Given this list of marker genes RND1, ARHGAP35, RPL30, RDX (NCBI Gene Id 5962), RPL29, CAP1, PTK2, RPL21, RPS6KA2, COL9A1, RPLP2, COL5A2, 5S rRNA, TUBB4A, PIK3R1, TREM2, NRAS, LDB1, TRIO, ARPC5, ZSWIM8, FRS2, SEMA4A, ABLIM1, RPS11, RPS16, SCN4A, RELN, PSMA1, TUBA8, GRB10, DCX, RPL10A, EIF4G1, ABL1, NGEF, MAGOHB, RPL26, UNC5D, FES, PSENEN, EPHB2, COL2A1, EFNA2, RPS23, CD24, AP2A1, RGMB, CSNK2B, RPL17, CLTB, ARPC3, TUBAL3, SRGAP1, CACNA1S, DSCAM (DS cell adhesion molecule), LHX9, VAV3, LIMK2, LAMB1, CACNA1H, SPTBN4, PSMD2, PSMB5, SCD5, PSMD6, RPS6KA6, MYL12B, ERBB2, PSMC2, PRKCQ, ABL2, RPS27L, TUBA1A, GSPT2, TRPC1, UNC5A, HJV, PLXNA1, MYH14, COL4A2, LYN, GSK3B, DLG1, EIF4A3, ROBO2, RET, VASP, ADRM1, RPS27A, CD72, DOK2, UBA52, KCNQ2, HOXA2, AP2M1, RPL35, ROCK1, NTN1, RPL31, RPL27A, COL4A5, SCN9A, AP2B1, MET, RPL18A, DPYSL4, EVL, CXCR4, SRGAP2, YES1, RPS7, PLCG1, CUL2, LHX3, NRP1, PSMB2, PIK3CA, NRP2, GSPT1, 5.8S rRNA, ST8SIA2, TUBA4A (NCBI Gene Id 93373), RPL28, RPL9, RAP1GAP, RPLP1, SDCBP, GFRA3, PMP22, PIK3R3, CREB1, PLXNC1, PSMC5, NFASC, EGFR (epidermal growth factor receptor), NTN4, PSMB1, VAV2, RHOA, PLXNB1, MAG, PRKACB, UPF3B, RPL23, TIAM1, AP2A2, RPS4Y2, LAMC1, FLRT3, ADGRG6, LHX2, RPL11, SCN1A, NCBP1, PSMD3, ARHGEF12, PSMD7, TLN1, CNTN6, TUBB2B, SHTN1, RPL34, SRGAP3, NAB2, EPHA2, RGMA, EFNB3, ARHGEF28, EPHB4, DAB1, CFL1, RPL13A, SHANK3, PLXNA2, COL5A3, VLDLR, DNM2, UNC5B, RPL32, RPS3, COL6A6, COL6A5, LYPLA2, DOK4, KCNQ3, LHX4, CDC42, TUBA3C, MAP2K2, ISL1, HMGCR, CASC3, TYROBP, RPL12, AP2S1, PIP5K1C, PSMA6, UBC, PSMA5 (NCBI Gene Id 5686), PLXNA3, PFN1, ARHGAP39, DRP2, EPHB1, DAG1, CNTNAP1 (NCBI Gene Id 8506), PSMC4, TUBA3E, ARHGEF7, MPZ, ARTN (artemin), PLXNA4, PTPRA, RRAS (NCBI Gene Id 6237), RPS9, SOS2, NCAN, NCAM1, MYH11, EFNA1, SCN3B, PTPN11, HRAS, NRCAM, ITGB1, HSPA8, RPL7, KIF4B, MMP2, RPL10L, SOS1, CLASP2, UTRN, RASA1, COL4A1, NCSTN, RPL3L, TUBA1C, SEMA6D, SLIT2, AGAP2, SPTA1, ROBO3, RPL37, PTPRC, SPTBN5, GRB2, SCN11A, PSPN, RPL36AL, NCK1, SH3KBP1, KRAS, UPF3A, KIF4A, RPL39L, SOX10, ITGB3, EPHA6 (NCBI Gene Id 647649), ITGA2, COL9A3, DOCK1, SEM1, GFRA2, TUBB1, RPLP0, TUBA1B, PAK4, ITGA2B, GRIN2B, RPS6, APH1B, PRX, SEMA3E, RPS18, POU3F1, L1CAM, TUBB2A, PSMC1, NCBP2, ITGA10, PDLIM7, ADGRV1, UBB, MAPK3, PAK3, SMARCA4, CLTCL1, PSMB7, HSP90AA1, ITSN1, COL6A1, RPS5, GRB7, NAB1, MYL9, APH1A, PSMA4, RPL27, CACNB3, PRKAR2A, MSN, TRPC5, NCK2, EPHB3, PSMD13, CRMP1, ARPC4, ARPC1B, RPS14, UNC5C, RPS15 (ribosomal protein S15), RHOC, CHL1, RPS19, ACTG1, PABPC1, SCN4B, PAK5, PSMD14, MYH9, SCN5A, ARPC1A, MBP, SPTBN1, CDK5R1, SRC, LAMA2, CAP2, MAPK1, RPL35A, GAP43, PSEN1, PSMD12, ITGAV, DSCAML1, RPL37A, RPS6KA1, ETF1, RPS28, RPS4Y1 (ribosomal protein S4 Y-linked 1), PSEN2, PAK6, WWTR1, KALRN, SCN3A, TEAD1, COL9A2, MAGOH, RPS17 (NCBI Gene Id 6218), ANK3, RPL23A, RANBP9 (NCBI Gene Id 10048), RPS6KA3, RPS20, GPC1, DPYSL3, RPL14, DNM3, SREBF2 (NCBI Gene Id 6721), AGRN, RPS4X, ABLIM2, SH3GL2, PRKACA, PSMD8, SCN2A, PRKACG, RPL4, 28S rRNA, WASL, EFNB1, EFNA4, COL3A1, 18S rRNA, RPS8, CDK5, EPHA7, PLXND1, CNTN2, RNPS1, CACNA1D, MMP9, MYO10, HSP90AB1, RPS10 (ribosomal protein S10), SDC2 (syndecan 2), MYL6, USP33, PSMA7, UPF2, ITGA5, CNTN1, CACNB2, RPL36A, PSMD1, ARPC2, TRPC3 (NCBI Gene Id 7222), GFRA1, PSMA3 (proteasome 20S subunit alpha 3), ARHGEF11 (NCBI Gene Id 9826), PLXNB3, TUBB8B, RHOB, RPL10, SCN8A, GAB1, RPL38, DCC, RPS24, PSMC6, SCN10A, TUBB8, TUBB3, RPL41, CSNK2A2, RPS3A, SPTBN2, PSMA2 (NCBI Gene Id 5683), COL5A1, GRIN1, EFNB2, EPHA4, CACNA1G, PPP3CB, CLASP1, MYL12A, CXCL12, RPS2, CSNK2A1, IRS2, PAK2, ELOC (NCBI Gene Id 6921), RPS26, PSMB4, COL6A3, PSMB3, RPL19, DLG4, DNM1, ACTR2 (actin related protein 2), RPS12, RPS13, ANK1, ROCK2, PITPNA, GDNF, GAB2, RPL22, CLTA, CLTC, PIK3CB, MAPK7, ADAM10, TRPC4, CACNA1C, RPL26L1, NRTN, RAC1, DPYSL5 (NCBI Gene Id 56896), DLG3, RBX1, HDAC2, SEMA5A, NUMB, SEMA6A, TRPC6, SEMA3A, ABLIM3, ITGA9, RPL5, CACNB4, SCN1B, GFRA4, TUBB4B, ENAH, SIAH2, PSMD11, FAU, PAK1, DOK5, EPHA3, EFNA5, ST8SIA4, ROBO3.1, SCN2B, COL4A4, EPHA5, PIK3CD, DOK1, DPYSL2, ACTB, PSMB6, SEMA4D, NELL2, TUBA3D, EFNA3, RPS6KA5, PRNP (NCBI Gene Id 96713), SPTAN1, EPHA8, ALCAM, RPL39, LAMA1, SHC3, FYN, RBM8A, RPL13 (NCBI Gene Id 6137), RPL18, CACNB1, RPL6, ACTR3, ITGA1, RPS6KA4, ROBO1, RPL3, DOK6, RPL7A, SPTB, EZR, SHC1, PSMC3, PFN2, TUBA4B, SEMA7A, FARP2, MYH10, COL6A2, RPS15A, ANK2, AKAP5, RPS25, SLIT3, POU3F2, CYP51A1, NEO1, RPS29, RPSA, YAP1, FGFR1, ELOB, RPS21, RPL8, RPL36, RPL15, CACNA1I, LIMK1, RPS27, TUBB6, GIT1, COL4A3, MAP2K1, EPHA1, RPL24, SIAH1, GJB1 (NCBI Gene Id 95372), SLIT1, RPL22L1, MYO9B, PIK3R2, EPHA10, TRPC7, SCN7A, MSI1, PRKCA, EPHB6, EGR2, here is a description of the gene set: part of: Developmental Biology Neurogenesis is the process by which neural stem cells give rise to neurons, and occurs both during embryonic and perinatal development as well as in specific brain lineages during adult life. studied in species Homo sapiens Reactome Pathway: Nervous system development